Given this list of marker genes Tbx2, Bmp4, Bmp7, Tacstd2, Wnt5a, Sulf1, Tnf, here is a description of the gene set: Mouse Gene Set: GOBP_NEGATIVE_REGULATION_OF_MORPHOGENESIS_OF_AN_EPITHELIUM Any process that stops, prevents or reduces the frequency, rate or extent of morphogenesis of an epithelium. species: Mus musculus